The following is a description of a gene set: Human Gene Set: DURANTE_ADULT_OLFACTORY_NEUROEPITHELIUM_DENDRITIC_CELLS from publication Durante MA, Kurtenbach S, Sargi ZB, Harbour JW, Choi R, Kurtenbach S, Goss GM, Matsunami H, Goldstein BJ (PMID 32066986) species: Homo sapiens, and this is the list of marker genes: FYB1, G0S2, LGALS2, FCN1, NEAT1, SLC11A1, PHACTR1, STXBP2, CORO1A, ITGB2 (NCBI Gene Id 3689), MNDA, EREG, FTL, NFKBIZ, LAPTM5, CD68, ATP2B1-AS1, CFD, VCAN, CD37, TNFSF13B, SPI1, AP1S2, CD44, CPVL, EVI2B, MS4A7, S100A8, S100A9, PTGS2, PYCARD, JAML, SERPINA1, LST1, DUSP1, CD48, CFP, FGR, LCP1, C5AR1, RIPOR2, GMFG (glia maturation factor gamma), FGL2, LSP1, CXCL8, EMP3, CST3, TIMP1, PSAP, S100A4, NAMPT, CD52, CARD16, MXD1, TREM1 (triggering receptor expressed on myeloid cells 1), IFITM2, CSTA, S100A12, NCF2, SOD2, CXCL2, CYBB, FPR1, SH3BGRL3, TNFAIP3, BCL2A1, TYMP, TYROBP, LILRB2, PLEK, STX11, PTPRE, OAZ1, TKT, TNFRSF1B, CD36, IGSF6, SRGN, PILRA, FCGR3A, SAMSN1, LYN, PELATON (NCBI Gene Id 100508225), COTL1, APOBEC3A, MS4A6A, POU2F2, CEBPB, CSF3R, NLRP3, CCL3, CYBA, CTSS, ZEB2, TNFAIP2 (NCBI Gene Id 7127), C1orf162, OSM, NCF1, NFKBIA, MPEG1, RGS2, AIF1, CLEC4E, HLA-DRA, PLAUR, FTH1, PTPRC, IL1B, CD14, IFI30, CLEC12A, GCA, CLEC7A, RNF149, FCER1G, ACTB